The following is a description of a gene set: species: Mus musculus The regrowth of cardiac muscle tissue to repair injured or damaged muscle fibers in the postnatal stage. Mouse Gene Set: GOBP_CARDIAC_MUSCLE_TISSUE_REGENERATION, and this is the list of marker genes: Gata4, Erbb4, Cdkn1b, Yap1, Cdkn1a